Given this list of marker genes Edc3, Dcp1a, Edc4 (NCBI Gene Id 234699), Zfp36l1, Zfp36, Dcp1b, here is a description of the gene set: studied in species Mus musculus Mouse Gene Set: GOBP_NUCLEAR_TRANSCRIBED_MRNA_CATABOLIC_PROCESS_DEADENYLATION_INDEPENDENT_DECAY A pathway of degradation of nuclear-transcribed mRNAs that proceeds through a series of steps that is independent of deadenylation, but requires decapping followed by transcript decay, and that can regulate mRNA stability.